Given this list of marker genes WNT10A, ARHGAP29, APC2, NSD1, PDGFRA, C1S, NECTIN1, RAD51 (NCBI Gene Id 5888), DLG1, SATB2, MESD, UBR1, RIPK4, GNB2, IRF6, PIGA, KCTD1, DVL3, BMP4 (NCBI Gene Id 652), LRP6, CREBBP, TP63, COBLL1, RAB23, ARHGEF38, MSX1, WDR35, RIC1, DLX4, TFAP2B (NCBI Gene Id 7021), OFD1, RECQL4, CDH1, C1R, EP300, here is a description of the gene set: Human Gene Set: HP_ABNORMAL_NUMBER_OF_PERMANENT_TEETH The presence of an altered number of of permanent teeth. species: Homo sapiens Abnormal number of permanent teeth